Given this list of marker genes Eif2a, Rnft2, Tmem67, Herpud1, Cav1, Rnft1, Atxn3, Bcap31, Tmx1, Eif2ak3, Ern1, Bag6, Sgta, Tmem259, Wfs1, Xbp1, Rnf185, Stub1, Ubqln2, Usp13, Ubqln1, here is a description of the gene set: species: Mus musculus Mouse Gene Set: GOBP_POSITIVE_REGULATION_OF_ERAD_PATHWAY Any process that activates or increases the frequency, rate or extent of ERAD pathway.